The following is a description of a gene set: Any process that stops, prevents or reduces the frequency, rate or extent of chemokine (C-X-C motif) ligand 2 production. Human Gene Set: GOBP_NEGATIVE_REGULATION_OF_CHEMOKINE_C_X_C_MOTIF_LIGAND_2_PRODUCTION studied in species Homo sapiens, and this is the list of marker genes: KLF4, MIR766, OAS3, MAP2K5, OAS1 (NCBI Gene Id 4938), MIR146A